Given this list of marker genes ALG12, ALG5, ALG10, UBE2J1, PGM3, FUT4, DPAGT1, MGAT3, ALG13, RPN1, DDOST, NUDT14, ALG8, FREY1, ALG14, GFPT1, FUT5, UGGT1, ALG1, ST3GAL1, MAN1C1 (NCBI Gene Id 57134), CWH43, ENTPD5, FUT8, ALG3, MGAT4A, ST6GAL1, ALG11, PMM1, MPDU1, DOLK, MGAT4D, ALG6 (ALG6 alpha-1,3-glucosyltransferase), FUT6, MGAT2, GAL3ST1, OSTC, GORASP1, FUT3, ALG10B, FUT9, TUSC3, DHDDS, NUS1, KRTCAP2, DERL3, B4GALT1, MGAT1, TMEM258, PMM2, EXT2, STT3A, ALG9, SLC39A8, MAGT1, DOLPP1, MGAT4B, B4GALNT2, MGAT5B, DPM1, ALG2, STT3B, RFT1, TMEM165, MGAT4C, GFPT2, SRD5A3, MOGS, OST4, MGAT5, DAD1, UGGT2, B4GALT7, RPN2, here is a description of the gene set: studied in species Homo sapiens Human Gene Set: GOBP_PROTEIN_N_LINKED_GLYCOSYLATION A protein glycosylation process in which a carbohydrate or carbohydrate derivative unit is added to a protein via the N4 atom of peptidyl-asparagine, the omega-N of arginine, or the N1' atom peptidyl-tryptophan.